Given this list of marker genes RIC1, TBC1D10B, SNX6, ANKFY1, STX10, PIKFYVE, WASHC2C (WASH complex subunit 2C), RAB14, SNX1, RAB6C, VPS29 (VPS29 retromer complex component), RAB41, PLEKHJ1, TBC1D17, RAB6D, LRRK2, SNX2, RAB4B, AP1S1, GBF1 (golgi brefeldin A resistant guanine nucleotide exchange factor 1), SORL1, VTI1B, GGA1, WIPF3, DENND5A, RBSN, ARL1, BAIAP3, UBE2O, STX5, SNX3, TBC1D14, CLTCL1, HEATR5A, VPS26A, BLTP3B, STX6, RUFY1, TRAPPC10, VPS52, ATP9A, PLEKHA3, USP7, YKT6, GOSR1, RHOBTB3, TMED9 (NCBI Gene Id 96645), STX16, DCTN1, GOLT1A, WASH3P, DENND2A, VPS26B, VPS35, RAB9B, WASHC2A, RAB29, RAB9A, VAMP3, EVI5 (NCBI Gene Id 7813), PREPL, VPS53, ERC1, SLC66A2, LMAN1, PHETA2, SNX8, VPS51, SGSM2, WASHC1, AP5Z1, RAB6A, TBC1D10C, ARFRP1, ARFIP1, VPS50, GCC2, RAB6B, SNX32, MAGEL2, PHETA1, RGP1, VTI1A, EIPR1, TBC1D23, GOLT1B, TMEM87B, TMEM87A, RAB7B, RNF126, EHD3, WASH6P, PRKN, RAB7A, TRIM27, SURF4, HEATR5B, TBC1D5, SNX12, RCSD1, SNX5, BET1L, VPS54, SPAG9, CLN5, ARL8B, CLTC, TBC1D10A, here is a description of the gene set: The directed movement of membrane-bounded vesicles from endosomes back to the trans-Golgi network where they are recycled for further rounds of transport. species: Homo sapiens Human Gene Set: GOBP_RETROGRADE_TRANSPORT_ENDOSOME_TO_GOLGI